Given this list of marker genes ITSN1, BTBD8, AP3D1, AP1G1, ITSN2, GRIPAP1, RAB7A, here is a description of the gene set: Human Gene Set: GOBP_SYNAPTIC_VESICLE_RECYCLING_VIA_ENDOSOME studied in species Homo sapiens Synaptic vesicle recycling where vesicles endocytosed via clathrin-coated pits re-acidify and refill with neurotransmitters after passing through an endosomal intermediate.